The following is a description of a gene set: from publication Howe DG, Blake JA, Bradford YM, Bult CJ, Calvi BR, Engel SR, Kadin JA, Kaufman TC, Kishore R, Laulederkind SJF, Lewis SE, Moxon SAT, Richardson JE, Smith C (PMID 30224793) Mouse genes annotated to HALLMARK_APICAL_SURFACE based on orthology mappings provided by the Alliance Genome Consortium species: Mus musculus Mouse Gene Set: HALLMARK_APICAL_SURFACE, and this is the list of marker genes: Adipor2, Hspb1, Rtn4rl1, Gstm5, Ntng1, Slc34a3, Gata3, Tmem8b, Ghrl, Efna5, Mdga1, Pkhd1, Shroom2, Thy1, Adam10, B4galt1, Brca1, Rhcg, Dcbld2 (discoidin, CUB and LCCL domain containing 2), Cd160, Lypd3, Lyn, Crybg1, Atp6v0a4, Il2rb, Il2rg, Pcsk9, Slc2a4, Plaur, Atp8b1, Srpx, Ephb4, Akap7, Slc22a12, Crocc, App, Cx3cl1, Flot2, Scube1, Afap1l2, Mal, Sulf2, Ncoa6, Gas1